Given this list of marker genes ZFYVE26, BTN3A3, CD2AP, HLA-DQB1, SEC24A, MRPL28, TBC1D5, PPT2, NKTR, ACOX1 (NCBI Gene Id 8308), VPS52, SEC62, PIM2, CDH2, SRSF8, PREP, VTI1B, DDR1, FSCN2, CDK8, RGL2 (ral guanine nucleotide dissociation stimulator like 2), DDX17, CCNG1, CCND1, IGLV2-14, NR2C1 (NCBI Gene Id 7181), RXRB, TNFRSF10B, MYB, FBXO21, COA1, CCNG2, SRSF6 (NCBI Gene Id 6431), here is a description of the gene set: Using a target gene approach, only a few host genetic risk factors for treatment-related myeloid leukemia (t-ML) have been defined. Gene expression microarrays allow for a more genome-wide approach to assess possible genetic risk factors for t-ML. We assessed gene expression profiles (n=12 625 probe sets) in diagnostic acute lymphoblastic leukemic cells from 228 children treated on protocols that included leukemogenic agents such as etoposide, 13 of whom developed t-ML. Expression of 68 probes, corresponding to genes, was significantly related to risk of t-ML. Hierarchical clustering of these probe sets clustered patients into three groups with 94, 122 and 12 patients, respectively; 12 of the 13 patients who went on to develop t-ML were overrepresented in the latter group (P<0.0001). A permutation test indicated a low likelihood that these probe sets and clusters were obtained by chance (P<0.001). Distinguishing genes included transcription-related oncogenes (v-Myb, Pax-5), cyclins (CCNG1, CCNG2 and CCND1) and histone HIST1H4C. Common transcription factor recognition elements among similarly up- or downregulated genes included several involved in hematopoietic differentiation or leukemogenesis (Maz, PU.1, ARNT). This approach has identified several genes whose expression distinguishes patients at risk of t-ML, and suggests targets for assessing germline predisposition to leukemogenesis. Human Gene Set: BOGNI_TREATMENT_RELATED_MYELOID_LEUKEMIA_DN from publication Bogni A, Cheng C, Liu W, Yang W, Pfeffer J, Mukatira S, French D, Downing JR, Pui CH, Relling MV (PMID 16341039) species: Homo sapiens Genes down-regulated in ALL (acute lymphoblastic leukemia) patients who developed t-ML (treatment related myeloid leukemia).